Given this list of marker genes NKX6-1, GATA6, HES1, NKX2-2, PAX6, RFX6, NKX6-2, ONECUT1, INSM1, NEUROD1, here is a description of the gene set: studied in species Homo sapiens The process in which relatively unspecialized cells acquire specialized structural and functional features of a pancreatic A cell. A pancreatic A cell is a cell in the pancreas that secretes glucagon. Human Gene Set: GOBP_PANCREATIC_A_CELL_DIFFERENTIATION